The following is a description of a gene set: species: Homo sapiens part of: Co-stimulation by CD28 CD28 binds to several intracellular signaling proteins, including PI3 kinase, Grb2, Gads, and ITK, which are crucial for amplifying the T cell activation signal initiated by the T-cell receptor (TCR). Grb2, in particular, works in tandem with Vav1 to enhance the activation of NFAT and AP-1 transcription factors, critical regulators of gene expression during T cell activation. CD28 costimulation significantly extends the duration and intensity of Vav1 phosphorylation and its localization at the plasma membrane compared to TCR activation alone, indicating that CD28 provides a sustained signal that enhances T cell responsiveness.<br>Vav1 plays a pivotal role in transducing signals from both TCR and CD28 to multiple downstream pathways, with a direct impact on cytoskeletal rearrangements. Upon activation, Vav1 triggers the small GTPases Rac1 and Cdc42, which lead to the activation of mitogen-activated protein kinases (MAPKs) like JNK and p38. In the context of CD28 signaling, these pathways are essential for regulating the expression of cytokines and promoting T cell proliferation and survival (Laura Inés Salazar-Fontana et al. 2003).<br>Additionally, Vav1's involvement in CD28 costimulation is critical for several other cellular processes, including calcium flux, ERK MAPK activation, NF-κB signaling, and the inside-out activation of the integrin LFA-1. This enhances T cell adhesion, clustering, and polarization, ultimately contributing to more effective immune responses. Thus, CD28 costimulation ensures that Vav1-mediated signals are robustly sustained, promoting optimal T cell activation and function. Reactome Pathway: CD28 dependent Vav1 pathway, and this is the list of marker genes: CD86, CDC42, LCK, CD80, RAC1, PAK3, PAK1, FYN, GRB2, VAV1, CD28, PAK2